Given this list of marker genes Mfsd4a (major facilitator superfamily domain containing 4A), Rap1a, Mllt11, Myom1, Esr1, Cpped1 (calcineurin-like phosphoesterase domain containing 1), Rgs1, Vegfc, Derl1, Dach2, Tle4, Spesp1, Wsb2, Lypd6, Il2ra, Parp11, Cxxc5, C030006K11Rik, Rab10, Hnrnpa3, Zfp85, Tfrc, Chtf8, Socs5, Gucy1a2, Sumo1, Ptpn4, Add3, Serpinb5, Spg21, Vps26b, Dlg2, Cltc, Esm1, Pde1c, Gvin1, Gpbp1, Col19a1, Ddx52, Fam174a, Aktip, Nap1l5 (nucleosome assembly protein 1-like 5), Scai, Cast, Vldlr, Zfp1008, Otulinl, Rpl22, Specc1, Mcph1 (NCBI Gene Id 71346), Rbm27, Camta1, Gata4, Vamp3, Fbxo33, Arhgef2, Ptp4a2, Sos1, Sat1, Psmd10, Dcaf7, Zbtb20, Galntl6, Unc5d, Mefv, Cobll1, Wasf1, Suco (NCBI Gene Id 98518), Zfp935, Pax1, Aurkb, Zswim6, Smim3, Epha4, Tent2, Lyn, Ankhd1, Pcdhb22, Sall2, Txlng, Klhdc8a, Mtmr6, Rpgrip1l, Npy1r, Dmtf1l, Chic1, Trpm3, Gramd2a, Hsbp1l1, Zfp772, Grhl1, Dync2i1, Grik2, Reps2, Naa15, Gvin2, Rangrf, Tead1, Arhgap21, Ogfrl1, Gabra1, Gpr183, Trp53bp2, Rnf138, Cacng2, Gpr50, Itga5, Txn2, Epb41l2, Rbm24, Akap12, Pappa, Cnga2, Baz1b, Dcaf1, Hycc1, Gata6, St13, Natd1, Pla2r1, Smg1, Frmpd4, here is a description of the gene set: Mouse Gene Set: MIR_22_5P species: Mus musculus Genes predicted to be targets of miRBase v22 microRNA mmu_miR_22_5p in miRDB v6.0 with MirTarget v4 prediction scores > 80 (high confidence targets). from publication Chen Y, Wang X (PMID 31504780)